The following is a description of a gene set: species: Homo sapiens Potassium Channels Human Gene Set: REACTOME_POTASSIUM_CHANNELS, and this is the list of marker genes: HCN2, KCNJ11, KCNMA1, KCNG4, KCNK4, KCNJ14, KCNK2, KCNK13, GNG12, KCNA4, HCN4, KCNJ3, KCNQ3, KCNG1, KCNH5, GNG4, GNG8, GNGT2, GNGT1, KCNC4, KCNAB2, KCNJ8, KCNJ15 (NCBI Gene Id 3772), KCNJ5, KCNMB4, KCNJ6, KCNH1, KCNF1, KCNA7, KCNK10, KCND3, KCNH8, KCNH3, GNG2, KCNA1, KCNG2, KCNK17, KCNQ1, KCNK18, KCNJ9, GNG11, KCNK1, KCNK3, GNG5, KCNC1, KCNH2, KCNB1 (potassium voltage-gated channel subfamily B member 1), KCNN2, KCNA6, ABCC9, KCNC2, GNG7, KCNH6, GNB2, KCNA2, KCNQ4, KCNK6, KCNA10, KCNN3, KCNG3, GABBR2, GNG3, KCNJ10, KCNH7, KCNV2, HCN3, KCNK7, KCNAB1, ABCC8, GABBR1, KCNC3 (potassium voltage-gated channel subfamily C member 3), KCNH4 (NCBI Gene Id 23415), KCNQ5, KCNMB3, GNG10, KCNA3, GNB4, GNB5, KCNA5, KCND1, KCNS1, HCN1, KCNS2, KCNK16, KCNMB1, KCNJ2, KCNN4, KCNJ4, GNB1, KCNN1, KCND2, KCNAB3, KCNJ1, KCNJ12, KCNB2, KCNV1, KCNJ16, KCNK9, GNG13, KCNMB2, KCNS3, KCNQ2, GNB3